The following is a description of a gene set: species: Homo sapiens Genes in the cancer module 69. Human Gene Set: MODULE_69, and this is the list of marker genes: PITPNC1, NRL, WSB2, TMEM144, DPYD (NCBI Gene Id 1806), REPIN1, ZFP41, PRDM8, NME1 (NCBI Gene Id 7794), CAMKV, SEPTIN2, MAPK4, MOB4, SPNS1, TESPA1, NMNAT1, CYP2C9, RBM7, PDCD2L, CEBPZ, CYYR1, EEF1D, HSD17B12, CENPK, FBXW4, DIAPH2, CCL19, NXPH4, LAMB3, TNFRSF13C, SH2B3, DDX17 (NCBI Gene Id 10521), TIMP4, NXF1 (nuclear RNA export factor 1), EGFR, BPIFB2, TRIM14, TOR4A, SLX4, FGFR3, PTPRT, TMEM248, SCARA3 (NCBI Gene Id 7992), TMEM121B, STAT5A, SPMAP2, HACD1, MCMBP, UNC79, ANKRD13A, TMED3, LARP1, ZBTB7A, POLDIP3 (DNA polymerase delta interacting protein 3), CHD1, ZNF264, OR7E12P, ZCCHC4, CCAR2, DDX60, PLAAT4, CST1, FLJ13224, AURKAIP1, DDX11, KLHL41, PIKFYVE, CYP2B7P, TRAF3, CD302, MOCOS, SLC11A2, TAL1, SURF6, AMZ2, CDK11A, DIO3, TMEM161A, PI4K2B, CCDC90B, KATNIP, ITM2C (NCBI Gene Id 9523), RNASEL, HS1BP3 (NCBI Gene Id 64342), MYBL2, FABP2, COCH, FGD6, BPTF, IGKC (immunoglobulin kappa constant), DEXI (Dexi homolog), ISCU, ACSBG1 (NCBI Gene Id 23205), PYGB, ZKSCAN7 (NCBI Gene Id 80241), VIT, HINT3, BCL2L13 (NCBI Gene Id 25779), ITK, ITGA8, KRT19, PLGLB2, NUP54, UTP11, FAM220A (family with sequence similarity 220 member A), ATXN7, MST1R, PLIN1, TMEM250, EARS2, CUL9, STAMBPL1, CMTM6, C19orf73, CELP, COPE, EGLN1, DHODH, SLC43A1, FNBP4, XRN2, UBE2J1, MTTP, EDN1, MRPL27, RALGPS2, TMEM120A, USP36, CAND1 (NCBI Gene Id 55832), ARHGAP45, NHSL3, GEMIN7, PKIA, SDC3 (syndecan 3), DYNC2LI1, SLC17A8 (solute carrier family 17 member 8), CEP55, SNTB2, LRRC19, GLB1L, BFSP2-AS1, ITGB5, DHRS12, LINC00160, NR2E1, SIAH1, ADIPOR2, PRPF39, HBE1, LANCL2, SMAD3, FPR2, ABI3 (ABI family member 3), CAPRIN1, BCR, TNFRSF17, ESPN, SLMAP, PHAX, MRPS15, TMEM97, BRAP, BHLHE40, LRRC4C, USP6, EPS15L1, TTYH2, ELAC1, DIRAS2, PTPRF, LAIR1, ZGRF1, EYA3, KDM4D, FOSL2, COL6A3, GEMIN4, CTSZ, CDK16, GJC2, ZNF318, PNMA8A, NUP58, LMO7, PCGF1, RHPN1, TLN1 (NCBI Gene Id 7094), LRP3, KDM5B, KLHL36, TDP1, NUTM2F, ZBTB5, GPR137B, THUMPD1, LDAH (lipid droplet associated hydrolase), TSLP, MED14, HNRNPU, ASXL2, TRIM48, SLC9A6, NANS, SFT2D3, BPIFA1, CCNG1, MTMR12, DCLK1, ACTR6 (NCBI Gene Id 64431), SLC26A8, PHIP, SATB1, MAGEL2, ZNF202, QSER1 (glutamine and serine rich 1), GJA1, UFL1, ATRN, CLUH, USP30, CCNH, C17orf75, ZNF117, HOXC4, SF3A1, POU6F2, ABCC1, MBD5, PYCR3, BEND5, TFAP4, TRIM7, RNF220, BEGAIN, CHD9, PGLYRP2, ARID5A, REV3L (REV3 like, DNA directed polymerase zeta catalytic subunit), PCDHB7, ATG16L1, CD1A, POGLUT2 (NCBI Gene Id 79070), PPP1R14D, BARD1, NEIL1, KIF18A, CELF2, MREG, PIP4K2C, CAAP1, TMLHE, MICALL1, WRNIP1, UFSP2, AMIGO1, BSDC1, KIAA2013, MXRA8, PNPLA2, ARHGAP15 (NCBI Gene Id 55843), PTX3, AMOTL2, SP140L, SOX1, RARB, ACVR1, TIMELESS, ATP8A2, PDCD5, NMT1, EPCIP, IL18R1, CYP2A7, PAPOLA, ALDOA, NECAP2, PPP1CB, NSUN3, CCNL1, TRMT6, GPR68, WDR19, SLC19A1, TBC1D9, PLA2G2A, SARAF (NCBI Gene Id 95251), SAV1, CHL1, WDR46, GRAPL-AS1, ZMYM6, GREB1, MYEF2, CYP1A1, COQ8A, AGAP2, C1orf116, PCED1B, BCL2L14, EPHA7, PDCD6, NPY1R, ILRUN, SPAG9, FURIN, CCDC102A, DCX, NELFB, GATA3, NOL7, ELOVL2, SELP, MCTS1, CHST1 (NCBI Gene Id 8534), TSC22D3, CLCF1, ATG2A, TRABD, FAF1, LYL1, MAP4, PDE4D, FEM1C, RFX7, EIF2B4, CDH5, ANKRD1, IFI27, BRIP1, CCDC85C, PPP4R2 (protein phosphatase 4 regulatory subunit 2), ZNF292, FBXO11, GSTZ1, ERVMER34-1, P4HTM, AASS (aminoadipate-semialdehyde synthase), PLEKHM2, SOAT2, LY86, PAWR, SYCP2, MRPL36, QKI, CITED2, MPRIP, ERMN, DNAJC12, RXRA, S100A5, CXCL8, MAP1S (microtubule associated protein 1S), ISYNA1, ZNF566 (zinc finger protein 566), LHPP, MORC3, NACAD, STAT3, OSBPL9, PLEKHF2, INO80B, CORIN, CD8A, ABHD17C, MAP6D1, ZMAT4, ACKR1, ITGAM, IMMT, MRPL18, RERE, HNRNPDL, SOX21, GOLGA4, MSX1, KLF13, CCDC81, PRPF38B (pre-mRNA processing factor 38B), CPNE1, IL1A, MED12L, BAG3, SENP1, MRPL47, SH3BP2, MAPKBP1, NCOA7, TMEM62, OTOR, ABL2, BASP1, AKAP8L, IPCEF1 (NCBI Gene Id 26034), IFT80, TNFSF4, CIP2A, ALDH1B1, CEP162, KAT2B, BHMT2, CCBE1, VAV1, HMGN5, ZNF106, OBSCN, DNAAF4, CD9, TYMP, RBAK, SUGP2, CCL13, PARS2, SOX6, ITGA4, ALG6, PROM1, GPATCH3, GPSM3 (NCBI Gene Id 63940), CD1D, SELE, GABPB1-IT1 (NCBI Gene Id 55056), PIF1, ENPP1, DCANP1, RFC2, SLC22A3, BTN2A1, IL1RL1, NDRG2, SV2B, EDNRB, IWS1, NGF, STRIP2, SCD, SLC5A4, TP53, GSTM1, CHAF1A, WDR25, ELSPBP1, TTF2, PCSK5, SLC25A27, OR2A1, MYL12A, CHST9, CDH22, SMG7, BMX, GALNT3, PTPRZ1, RRAGD, PORCN, MED25, GGA2, OXGR1, FAR2, ELMO1, FMN1, CNKSR2, NEPRO, CCDC134, MMP7, ZMYM5, MYH1, RNF103, FOS, XPO4, LMTK3, HYAL2, PPIL2, DCTN3, IL1R2, CLEC2B, KATNAL1, PTGS2, ATG4D (autophagy related 4D cysteine peptidase), VEGFC (vascular endothelial growth factor C), CDH4, RPRM, PLEKHG1, NOP53, KCNE4, MAGED4B, ZNF638, EFCC1, INIP, APTX, SIPA1L3, KLHL4, PRDM1, TUBA4A (tubulin alpha 4a), CSF1, FGFR2, UGCG, SSBP4, ART3, GJA5, SNRNP25, MICB, CDH13, HIVEP2, STRN, GLT8D1, DES (desmin), RABGAP1, LEPROTL1, BAIAP3, MMP14, SRSF5, CYP2E1, GSTM4, METTL22, SLITRK1, ZNF143, PHF3, ELOB, CACNA2D3, YWHAB, ERLIN2, SLAMF7 (SLAM family member 7, NCBI Gene Id 57823), TBC1D8B, NFIL3, DZIP3, F3, SNX5